Given this list of marker genes AKT2, VKORC1L1, NR1H4, ANGPTL4 (angiopoietin like 4), CEACAM1, DHRS9, CAV1, NQO1, TRIB3, STAR, TPI1, TWIST1, MIR132, UGT1A3, TYSND1, ACACB, PANK2, RDH10, CYP19A1, HSD17B6, SRD5A1, DAB2, ELOVL5, ADM, COQ3, AKR1C3, COQ4, MIR182, BMP2, PPARA, FMO1, TDO2, EIF6, AKR1A1 (aldo-keto reductase family 1 member A1), IL1B, MFSD2A (MFSD2 lysolipid transporter A, lysophospholipid), PGK1, ADIPOQ, SCAP, DCAF5, LONP2, PTGS2, DGAT2, SIRT4, APOC3, GIP, ACADL, EDNRB, CLCN2, DHRS4, MIR33A, PIBF1, SIRT5, PARK7, PDK2, LHB, PROX1, AKR1B1, COQ9, GHSR, MIR30C1, KYAT1, NCOR2, WNT4, MLYCD, BMP5, CYP11B2, PDK3, FSHB, KMO, ALDH8A1, CYP46A1, AVP, PPARD, MIR185, KDSR, COQ6, KLHL25 (NCBI Gene Id 64410), FDX2, FGF19, NDUFA9, GPIHBP1, ADCK2, GATD1, MIR766, CYP4F2, REST, SREBF1, INHBA, SIRT6, UGT1A8, NR1H2, MLXIPL, CBR4, AVPR1A, SNCA, UBR4, AFMID, VKORC1, PLA2G3, GGCX, DGKQ, ADH4, CD74, SOX9, NFE2L1 (NFE2 like bZIP transcription factor 1), AKR1C1, HSD17B3, UGT1A6, PRMT3 (protein arginine methyltransferase 3), CYP2B6, SCP2, UGT1A7, SLC45A3, BGLAP, APOA4, CREB1, PPARG, UGT1A10, FMO2, PDK1, SLC22A13, ERLIN2, GLO1, RTN4IP1, PDSS2, DKK3, ABCD2, CBR1, CYP11B1, AKT1, APOC2, H6PD, NR1D1, NR1H3, EGR1, CYP4F12, KAT2B, FABP3, UBIAD1, CYP4F3, PLAA, AKR7A2, CPT1A, FDXR, APOA5, CES1 (NCBI Gene Id 1067), HSD11B2, CYP7A1, SULT1C4, ABCB11, KYAT3, STARD7, MIR548P, PPTC7, BMP6, PPARGC1A (PPARG coactivator 1 alpha), MIR342, MID1IP1, AKR1C4, COQ8B, HSD17B1, MIR96, UGT1A1, SCNN1B, AKR1B10, WDTC1, APPL2, SIRT2, AFP, ERFE, CBR3, STARD3, PDSS1, IDO2, FMO4, CYP4F8, AIFM2, GDF15, INSIG2, ERLIN1, ABCD1, COQ5, BRCA1, PLIN5, MTLN, INSIG1, COQ7, MALRD1, IRS2, ACADVL (NCBI Gene Id 37), FABP5, CYP17A1, OXCT1, DKKL1, SRD5A2, HSD17B10, TPK1, AKR1C2, COQ8A, LPGAT1, HAGH, KYNU, CYP11A1, PRKG1 (NCBI Gene Id 5592), SIRT1, GPRC6A, ETFBKMT, APOC1, IDO1, BCKDK, NCOR1, AADAT (aminoadipate aminotransferase), IRS1, CRYZL1, COQ2, PRKAG2, UGT1A9, NMT1 (NCBI Gene Id 4836), MIR204, TREX1, CYP4F11, FGFR4 (NCBI Gene Id 2264), INS, STAT5B, NQO2, UGT1A4, PNKD (NCBI Gene Id 87830), STARD4, PDK4, CACNA1H, here is a description of the gene set: Human Gene Set: GOBP_KETONE_METABOLIC_PROCESS The chemical reactions and pathways involving any of a class of organic compounds that contain the carbonyl group, CO, and in which the carbonyl group is bonded only to carbon atoms, as carried out by individual cells. The general formula for a ketone is RCOR, where R and R are alkyl or aryl groups. studied in species Homo sapiens